Given this list of marker genes Sp140, Socs1, Cd274, Irf8, Calhm6, Rtp4, Plac8, Oas3, Isg15, Tgtp2, Psma2 (proteasome subunit alpha 2), Samhd1, Slfn1, Xaf1, Parp14, Ifi213, Tapbp, Notch1, Parp9, Sp110, Psmb10 (proteasome (prosome, macropain) subunit, beta type 10), Eif5a, Wars1, Stat1, Irf1, Irf7, Psme2, H2-DMa, Ifi203, Ifit3, Tap2, Oasl2, Samd9l, Ifi27l2a, Ifi35, Gimap4, Apobec3, Tap1, Gbp9, Ly6e, Irgm1, Stat3, Igtp (NCBI Gene Id 16145), H2-D1, Ppa1, Dbnl (NCBI Gene Id 13169), Bst2, Rnf213, Gbp8, Ctss, Irgm2, Irf2, Gbp5, Gbp7 (NCBI Gene Id 229900), Gbp4, Gbp2, Zbp1, Dtx3l, Selenow, Ly6a, Ssbp2, Tapbpl, B2m, Plaat3, H2-T23, Psmb9, Lgals3bp, Iigp1, Nlrc5, Ifi206, Gbp6, Pfn1, Phgdh, Psmb8, H2-Q4, Plgrkt, Gbp3, Mndal, Idnk, Ifi47, Nmi, Tmsb10, H2-T22, Psme1, here is a description of the gene set: from publication Cui A, Huang T, Li S, Ma A, Pérez JL, Sander C, Keskin DB, Wu CJ, Fraenkel E, Hacohen N (PMID 38057668) Cytokines mediate cell-cell communication in the immune system and represent important therapeutic targets. A myriad of studies have highlighted their central role in immune function, yet we lack a global view of the cellular responses of each immune cell type to each cytokine. To address this gap, the authors created the Immune Dictionary, a compendium of single-cell transcriptomic profiles of more than 17 immune cell types in response to each of 86 cytokines (>1,400 cytokine-cell type combinations) in mouse lymph nodes in vivo. A cytokine-centric view of the dictionary revealed that most cytokines induce highly cell-type-specific responses. For example, the inflammatory cytokine interleukin-1β induces distinct gene programmes in almost every cell type. A cell-type-centric view of the dictionary identified more than 66 cytokine-driven cellular polarization states across immune cell types, including previously uncharacterized states such as an interleukin-18-induced polyfunctional natural killer cell state. species: Mus musculus Genes positively differentially expressed in cell type: CD8+ T cell upon treatment with cytokine: IFN-γ in mouse lymph nodes in vivo. Mouse Gene Set: CUI_T_CELL_CD8_IFNG_RESPONSE_UP